The following is a description of a gene set: Human Gene Set: KEGG_MEDICUS_VARIANT_AMPLIFIED_PDGFR_TO_RAS_ERK_SIGNALING_PATHWAY Pathway Definition from KEGG: PDGFR* -> GRB2 -> SOS -> RAS -> RAF -> MEK -> ERK species: Homo sapiens Amplified PDGFR to RAS-ERK signaling pathway. Pathway ID: N00018. Pathway type: Variant. Pathway class: nt06273 Glioma., and this is the list of marker genes: MAP2K2, NRAS, ARAF, BRAF, KRAS, MAP2K1, MAPK1, PDGFRA (NCBI Gene Id 5156), SOS1, MAPK3, RAF1, GRB2, SOS2, HRAS